The following is a description of a gene set: Any process that stops, prevents, or reduces the frequency, rate, or extent of interleukin-5 production. Mouse Gene Set: GOBP_NEGATIVE_REGULATION_OF_INTERLEUKIN_5_PRODUCTION species: Mus musculus, and this is the list of marker genes: Scgb1a1, Lilrb4b, Epx, Tnfrsf21, Lef1, Lilrb4a, Foxp3